Given this list of marker genes Gclc, Gad1, Grin2d, Grin2b, Cps1, Slc1a1, Slc1a3, Grin1, Gad2, Glul, Cep104, Grin2a (NCBI Gene Id 14811), Grik1, Grm7, here is a description of the gene set: Mouse Gene Set: GOMF_GLUTAMATE_BINDING studied in species Mus musculus Binding to glutamate, the anion of 2-aminopentanedioic acid.